The following is a description of a gene set: species: Mus musculus Mouse Gene Set: GOBP_POSITIVE_REGULATION_OF_TOR_SIGNALING Any process that activates or increases the frequency, rate or extent of TOR signaling., and this is the list of marker genes: Rragc, Akt1, Wdr24, Mios, Gpr137c, Usp9x, Foxp1, Pih1d1, Akt3, Fnip2, Pip4p1, Rbx1, Slc38a9, Rraga, Gpr137b, Mat2a, Rheb, Rragd, Prmt1, Kdr, Lamtor1, Sec13, Usp32, Trem2, Pim1, Rbx1-ps, Xbp1, Reln, Src, Gas6, Klhl22, Stambpl1, Lars1, Otud7b, Ogt, Flcn, Golph3, Hdac3, Fnip1, Lamtor4, Smcr8, Rictor, Gpr137, Rnf167, Shq1 (NCBI Gene Id 72171), Rps6kb1, Seh1l, Bmt2, Rptor, Csnk1a1, F3, Cul3, Ctns, Lamtor5, Srms, Otud5, Ccl5, F10, Lamtor3, Mlst8, Sik3, Lep, Htr6 (NCBI Gene Id 15565), F7, Usp4, Castor1, Wac, Lin28a, Nckap1l, Tbk1, Ep300, Gpr155, Wdr59, Clec16a, Lamtor2, Otub1, Syk, Sesn2, Rragb